The following is a description of a gene set: Human Gene Set: GOBP_PROCESS_UTILIZING_AUTOPHAGIC_MECHANISM A cellular process involving delivery of a portion of the cytoplasm to lysosomes or to the plant or fungal vacuole that does not involve direct transport through the endocytic or vacuolar protein sorting (Vps) pathways. This process typically leads to degradation of the cargo; however, it can also be used to deliver resident proteins, such as in the cytoplasm-to-vacuole targeting (Cvt) pathway. species: Homo sapiens, and this is the list of marker genes: WIPI1 (WD repeat domain, phosphoinositide interacting 1), SUPT5H, ATG4D, STAM, MTCL1, WDR81, VPS28, PAFAH1B2, ATP6V0B, SNX18, VPS39, RAB3GAP1, SPART, ARHGAP26, CSNK2A1, PIK3CA, ELAPOR1, NRBP2 (nuclear receptor binding protein 2), SESN3, MFSD8, INHBA, MIR199A1, USP36, CDK5, FOXO1, HDAC6, NEDD4, AKT1, ATP6V1B1, OSBPL7, NPRL3, S100A8, EIF4G3, BCL2L1, SNX5, ATP6V1A, SPG11, IKBKG, SRPX, TSPO, NBR1, RPTOR, ATG16L1, LEP, TPCN1, SYT11, VPS35, RAB5A, TAX1BP1, CERS1, TMEM41B, NPRL2, NIPSNAP1, ATG13, CLTC, HIF1A, SNAP29, PLEKHM1, BAG3, WDFY4, RNF41, VIPAS39, SLC7A5, VHL, TBK1, LRRK2, ATP6V1E2, VPS41, TSC1, ATP6V0E2, RETREG1 (reticulophagy regulator 1), BECN1, CHMP4BP1, CDK5R1, AP5Z1, SREBF1, STAM2, NAT8B, SNF8, FBXL4, SCOC (short coiled-coil protein), NOD2, EMC6, CSNK2A2, TBC1D12, TRIM22, ATP6V0D2 (NCBI Gene Id 245972), WDFY3, RGS19, CALCOCO2, STX17, RAB43, MAGEA3, LIX1L, QSOX1, SNX6, ZMPSTE24, EHMT2, SNX7, NUPR1, VPS29, MAP3K7, HK2, BCL2L13, TCIRG1 (T cell immune regulator 1, ATPase H+ transporting V0 subunit a3), DDIT3, CDKN2A, ATP6V1B2, SPATA18, HMOX1, EFNB1, MTMR14, VTI1A, STK38L (NCBI Gene Id 23012), CHMP1A, TRAF6, VPS37B, HUWE1, NIPSNAP3A, CDK5RAP3, FOXK2, TSG101 (tumor susceptibility 101), PACS2, GPSM1, RAB33A, CPTP, MID2, ATP6V1H, HAX1, STX12, TREM2, IFT20, UBA5, ATP6V0A1, ERFE, MAP1LC3B, SLC35D3, SLC25A4, ATG10, RRAGA, PIM2, SNAPIN, ZFYVE26, ATP6V1C1, VAMP8, TP53INP2, MTMR9, TIMM23, TAB3, SLC25A46, BMF, PRKD1, ATP6V1G2, KIF25, ZC3H12A, RAB39A, RNF213, VTI1B, MTMR3, ATF6, RRAGC, VPS37D, TRIM65, UBQLN1, PHF23, RUBCNL, MOAP1, MFN2, WDR41, VPS11, MAP1LC3C, TOLLIP, EIF4G1, MAPK15, CHMP4A, POLDIP2, TOM1, MAGEA6, PPTC7, STBD1, VCP, BOK, MEFV, LZTS1, DCN, GABARAPL3, ATP13A2 (NCBI Gene Id 63919), FKBP8, TECPR1 (NCBI Gene Id 25851), ULK3, SIRT1, SMCR8, PRKAA1, VPS13A, FLCN, SESN2, RALB, UBE2A (ubiquitin conjugating enzyme E2 A), EIF2AK1, CLU, USP10, KLHL22, OGT, UBXN2A, TSC2, GBA1, LYN, ATG2B, PEX2, PEX5, STUB1, SNX14, LEPR, CHMP1B, RETREG3, ATG16L2, PRKN, EEF1A1, VPS4A, TRIM5, RNF166, EPG5 (ectopic P-granules 5 autophagy tethering factor), PIK3R4, TP53INP1, SREBF2, EIF4G2, IRGQ, RNF152, MET, ATG4C, ATP6V0A2, UFC1, PINK1, MCOLN1, CREG1, USP20, TMEM208, FOXK1, NSFL1C, SNX4, SUPT20H, SH3BP4, VPS33B, PIP4K2C, GAPDH, ATG3, PIK3C2A, TBC1D17, FBXW7, AMBRA1 (NCBI Gene Id 55626), EVA1A, UVRAG, FYCO1, LIX1, TRIM8, ADRA1A, CHMP7, TGFBRAP1, HGF, TM9SF1, ABL2, ITPR1, DEPP1, VTA1, MCL1, UBR4, BCL2, EIF4E, CAPNS1, STK11, EPHB2, RHEB, GPR137, MAPK3, ABI2, RMC1 (regulator of MON1-CCZ1), AFG2B, MTOR, KAT8, DAP, XPA, VDAC1, IL10, ZDHHC19, RAB7A, ZNF418, VPS26B, CTTN, PARL, ITGB4, TIGAR, HTRA2, RRAGD (NCBI Gene Id 58528), FOXO3, CHMP5 (NCBI Gene Id 51612), FBXO7, VPS4B, SMURF1, ILRUN, TLK2, SNX30, FUNDC1, VPS13C, TAB2, PIP4K2B, PIK3C3, UFM1 (NCBI Gene Id 51569), MTDH, UFL1, STAT3, DRD2, LACRT, CASP3 (caspase 3), ATG12, LRSAM1, ATG101, IL10RA, ATP2A2, KDR, ATG2A, ATP6V0C, NOD1, GABARAPL2, VPS25, EEF1A2, TRIM27, LRBA (NCBI Gene Id 987), EIF2S1, FUNDC2, CTSA, MAP2K1, KDM4A (NCBI Gene Id 9682), DAPL1, MAPK8, PIK3C2B, GNAI3, PIK3R2, RAB39B, TFEB, SQSTM1, ATP6V0D1, HERC1, GFAP, TRIM23, RUFY4, FNBP1L, CTSK, IFNG, RAB33B, PSEN1, RAB23, ATP6V0E1, EXOC4, CAPN1, ATP6V1G1 (NCBI Gene Id 9550), ATG9B, SCFD1, HDAC10, RNF186, HSP90AA1, PYCARD, ATG7, DELE1, NPC1, DCAF12, CAMKK2 (calcium/calmodulin dependent protein kinase kinase 2), TRIM21, DNM2, VPS51, VPS37C, LAMP2, PJVK, ZNRF2, KAT5, TMEM150B, ATG9A, VPS18, GABARAPL1 (GABA type A receptor associated protein like 1), RIPK2, RAB2A, ABL1 (NCBI Gene Id 25), MUL1, UBQLN4, PRKACA, ERN1, DRAM1, PIP4K2A, RAB19, RAB1A (NCBI Gene Id 5861), RNF31, LARP1, WDR45B, EXOC8, PRKAA2, SNRNP70, TEX264, CHMP6, GPR137B, CISD2, CDK16, LAMP3, RAB37, PGAM5, CALM1, PHB2, CLN3, ATG4B, USP13, MTCL2, LGALS8, RRAGB, PIKFYVE, BECN2, ELP6, IRGM, UMOD, RB1CC1, MAPT, EI24, TMEM59 (transmembrane protein 59), ATG4A, PTPN22, VPS33A, CHMP4B, ULK2 (NCBI Gene Id 9706), DHRSX, TP53, ACER2, TBC1D25, SNCA, ZKSCAN3, RASIP1, EXOC1, TRIM32, VMP1, PLK3, CHMP2A, TICAM1, DAPK2, CHMP3, HAP1, ATP6V1D (NCBI Gene Id 51382), SVIP, DRAM2, TPCN2, EP300, KLHL3, ACBD5, FBXL2, ZNRF1, CDC37, GRAMD1A, ELAVL1, MVB12A, SIRT2, RNF185, HMGB1, GSK3A, ARSB, ZFYVE1, MTCL3, ATG5, PARK7, PLK2, CCNY, NHLRC1, SETD2, WDR45, IFI16, IRF8, CHMP4C, EPM2A, HSPB8, AUP1, GSK3B, TRIM17, RPGR, SPTLC1, USP33, CD84, CRYBA1 (crystallin beta A1), ARFIP2, VPS16, ADCY10 (adenylate cyclase 10), SPTLC2, ATG14, SLC25A5, BCAS3, RAB2B, RAB24, WAC, ANXA7, STING1, PIK3CB, C19orf12, MAP1LC3B2, PSAP, ATP6V1E1, ARL8B, CTSD, XBP1, TECPR2, RAB1B, PDCD6IP (programmed cell death 6 interacting protein), WASHC1, CISD1, RIMOC1, ENDOG, YOD1, C6orf89, TOMM7, TRAPPC4, MARK2, VAMP7, FEZ1, DEPDC5, SBF2, DAPK3, ATP6V1C2, CHMP2B, WDR24, ROCK1 (Rho associated coiled-coil containing protein kinase 1), BNIP3L, DEPTOR, ORMDL3, MTMR8, TBC1D5, AP4M1, MTM1, NRBF2, WIPI2, KEAP1, TBC1D14, DNM1L, LRPPRC, SRC (NCBI Gene Id 6714), VPS36, RAB8A, DAPK1, GATA4, UBXN6, NLRP6, WDR6, GABARAP, MAP1S, RETREG2, SPATA33, RAB3GAP2, TMEM74 (NCBI Gene Id 157753), BAD, CLEC16A, RBX1, EXOC7, CHEK2, USP30, WDR47, GOLGA2, PLEKHF1, NIPSNAP2, MLST8, GAA, NAGLU, HTT, COL6A1, BNIP3, RAB1C, TMEM39A, VPS37A, DIAPH3, SESN1 (sestrin 1), RAB12, HGS, NIPSNAP3B, IFNB1, RUBCN, MAP1LC3A, ERCC4, HSPB1, VPS13D, VPS26A, TRIB3, RNF5, LYPLA1, HSPA8, SH3GLB1, DNAJC16, PLAA, C9orf72, OPTN, ADRB2, WNK1, ULK1, ATP5IF1, SNX32 (NCBI Gene Id 254122), ATM, UBQLN2, UCHL1, S100A9, UBXN2B, FEZ2, TLR9, IFT88, IL4, DDRGK1, SEC22B, FZD5, TMBIM6, TRIM13, ARMC3